Given this list of marker genes GUCY1B1, BBC3, FHL2, MARK3, CNN3, RARA, PRKCH, IGF2BP3, IGHM, IGHD, GUCY1A1, RGS1, F13A1, here is a description of the gene set: Up-regulated in B lymphocytes from patients with ICF syndrom caused by mutations in DNMT3B compared to normals. species: Homo sapiens from publication Ehrlich M, Buchanan KL, Tsien F, Jiang G, Sun B, Uicker W, Weemaes CM, Smeets D, Sperling K, Belohradsky BH, Tommerup N, Misek DE, Rouillard JM, Kuick R, Hanash SM (PMID 11741835) ICF (immunodeficiency, centromeric region instability and facial anomalies) is a recessive disease caused by mutations in the DNA methyltransferase 3B gene (DNMT3B). Patients have immunodeficiency, chromosome 1 (Chr1) and Chr16 pericentromeric anomalies in mitogen-stimulated lymphocytes, a small decrease in overall genomic 5-methylcytosine levels and much hypomethylation of Chr1 and Chr16 juxtacentromeric heterochromatin. Microarray expression analysis was done on B-cell lymphoblastoid cell lines (LCLs) from ICF patients with diverse DNMT3B mutations and on control LCLs using oligonucleotide arrays for approximately 5600 different genes, 510 of which showed a lymphoid lineage-restricted expression pattern among several different lineages tested. A set of genes had consistent and significant ICF-specific changes in RNA levels. Half of these genes play a role in immune function. ICF-specific increases in immunoglobulin (Ig) heavy constant mu and delta RNA and cell surface IgM and IgD and decreases in Ig(gamma) and Ig(alpha) RNA and surface IgG and IgA indicate inhibition of the later steps of lymphocyte maturation. ICF-specific increases were seen in RNA for RGS1, a B-cell specific inhibitor of G-protein signaling implicated in negative regulation of B-cell migration, and in RNA for the pro-apoptotic protein kinase C eta gene. ICF-associated decreases were observed in RNAs encoding proteins involved in activation, migration or survival of lymphoid cells, namely, transcription factor negative regulator ID3, the enhancer-binding MEF2C, the iron regulatory transferrin receptor, integrin beta7, the stress protein heme oxygenase and the lymphocyte-specific tumor necrosis factor receptor family members 7 and 17. No differences in promoter methylation were seen between ICF and normal LCLs for three ICF upregulated genes and one downregulated gene by a quantitative methylation assay. Our data suggest that DNMT3B mutations in the ICF syndrome cause lymphogenesis-associated gene dysregulation by indirect effects on gene expression that interfere with normal lymphocyte signaling, maturation and migration. Human Gene Set: EHRLICH_ICF_SYNDROM_UP